The following is a description of a gene set: studied in species Homo sapiens Human Gene Set: WP_SPHINGOLIPID_PATHWAY Sphingolipid pathway, and this is the list of marker genes: SERINC1 (serine incorporator 1), SGPL1, PPP2CA, SPTLC1, PPP1CA, ACER1, CERS6, GBA1, UGT8, SPHK1 (NCBI Gene Id 8877), UGCG, CERS3, KDSR, SGMS1, SPTLC2, GBA2, B4GALT6, CERK, ASAH1, SPHK2, CERS5, SPTLC3, SGMS2, CERS2, GAL3ST1, SGPP2, ASAH2, CERT1, PLPP1, CERS4 (NCBI Gene Id 79603)